The following is a description of a gene set: Abnormally increased frequency (usually defined as three or more) loose or watery bowel movements a day. studied in species Homo sapiens Human Gene Set: HP_DIARRHEA Diarrhea, and this is the list of marker genes: BTK, HPS1, ERBB2, MGME1, SLC35C1, ARPC5, ITGB3, EPCAM, SLC19A1, CTLA4, ATP6V0A1, ERCC6, C5, APOA1, AIRE, SREBF1, CARMIL2, PCSK1, SON, SLC37A4, GREM1, TGFB1, B2M, CHD7, NAGLU, TOM1, POLA1, TYMP, OPLAH, JAK3, SLC22A5, CAV1, GLA, NHLRC2, SAR1B, HSD3B7, CPT1A, NR0B1, CDKN2A, SP110, ASL, TERT, ALDOB, SCNN1A, ADAM17, IGHM, TKFC, SLC51B, IL6, RIPK1, UQCRH, KARS1, USP7, BACH2, POLG, DOLK, NFKBIA, WDR1, IL21R (interleukin 21 receptor), ACTG2, FOXN1, IDS, DPM1 (NCBI Gene Id 8813), OTULIN (NCBI Gene Id 90268), MMUT, SUGCT, SCN11A, CLPB, TCF3, ALG2, B4GALT1, MRAP, GFI1, LRRC8A, ABCD1, MT-CO1, CD109, COG6, IRF1 (interferon regulatory factor 1), HNF4A, AGR2, SMARCD2, AK2, RMRP, SHARPIN, STK11, ETHE1, LRBA, MTR, ATRX, RYR3, SYNJ1, ANO1 (anoctamin 1), CDKN2B, NGF, MPV17, TLK2, SLC26A3, ABCB4, ADNP, CD55, HS3ST6, PLVAP, DBH, ATP1A3, IL2RA, AMACR, TMPRSS15, FAS, CCR1, GDNF, IDUA, RNF113A, VPS13C, HLA-B, TTC7A, HYOU1, NAGS (NCBI Gene Id 162417), IL12A-AS1, SLC10A2, TCN2 (transcobalamin 2), DES, TNFRSF13B, GATA6, CASP8, ACSL5 (NCBI Gene Id 51703), RFX6, TREH, HGSNAT, MCM10 (minichromosome maintenance 10 replication initiation factor), SLC12A3, MEFV, ATP8B1, SLC12A1, MEN1, EFL1, KRAS, RET (NCBI Gene Id 5979), REL, F9, ANTXR2, ALG3, IFNG, TTR, COG4, ORAI1, MADD, ACVRL1, NAA10, MT-CO2, TAOK1, SKIC3, AVP, C4B, IPO8, RECQL4 (RecQ like helicase 4), PKP1, SEMA3C, ELANE, CD3G, CPT2, IGKC, F8, ALDH4A1, ITGB4, MT-ND1, DGAT1, WAS, BRCA1, PHKG2, PIGT, ITGB2, RFXANK, SAT1 (NCBI Gene Id 6303), IL2RB, ERBB3, BMPR1A, ABCB11, CARD8, EDNRB, ACAT1, LIG3, BRCA2, IGLL1, NOD2, ATP7A, MC2R, ATP6AP1, RFX5, CR2 (NCBI Gene Id 1380), IL10RA, TET2, PPP2R5D (NCBI Gene Id 5528), AKR1D1, ANAPC1, IL10, ZNFX1, SERPING1, CBL, CFHR3 (complement factor H related 3), CARD11, CDKN1A, CHD8, PHKB, ARX, CCDC47, TFRC, IRF2BP2 (NCBI Gene Id 359948), COG7, SYK, TP53, RBCK1, G6PC1, IRAK1, CAD (carbamoyl-phosphate synthetase 2, aspartate transcarbamylase, and dihydroorotase), CD79B, DMPK, FCGR2A, ZAP70, RRM2B, ACSF3, UCHL1, VPS45, MVK, LIG4, IL2RG, IFNGR1, SLC25A13, PRKN, STX3, MYD88, STAT1, ARPC1B, FBP1, RAG2 (recombination activating 2), EDN3, SNCA, HLA-DQB1, IL12A, MAOA, IFIH1, PALLD, CPOX, PIK3CD, PERCC1, RNF168, ASXL1, GNS, SPINT2, AMN, SGSH, MT-TL1, GP1BB, PLEC, NLRC4, RACGAP1 (NCBI Gene Id 94651), SAMD9, MAP3K14 (mitogen-activated protein kinase kinase kinase 14), DNAJC6, SLC19A2, KMT5B, KNSTRN, BLNK, SDHD, MT-TH, NEUROG3, APC, MCM6, CFH, FOCAD, ITCH, IL37, IL21, CYP7B1, MTTP, NCF4, F5, DDC, IKBKB, KLRC4, PMM2, PSTPIP1, HACE1, ERAP1, RAG1, STAT4, CACNA1A, GINS1, ALG8, ATP5F1A, SLC7A7, CLMP, TNFRSF1A, ATP1A2, TNFRSF13C, CLCNKB, NR3C2, ALG1, GP1BA, SCN9A, RFXAP, CD3D, SLC5A1, ITGA2B, CYP27A1, DOCK11, ADA, ALK, FAH, PODXL, SLCO2A1, EGFR, IKBKG, LIN28B, SPP1, MLYCD, PIK3R1, MYO5B, NRTN, SLC46A1, TSHR, LCK, ALAD, HEXB, ITGA2, CD247, MT-CO3, ENG, IRF4, SPI1, HEATR3, LRRK2, UBAC2, DCLRE1C, ZFYVE19, LIPA (lipase A, lysosomal acid type), PALB2, MT-TF (NCBI Gene Id 4558), IL6ST, PINK1, ZBTB24, STAT3, SRSF2, KIF23, PSMB10, PIK3CG, ACADM, ELP1, HTRA2 (HtrA serine peptidase 2), IKZF1, STAR, PGM1, HBB, MT-ND6, MPI (NCBI Gene Id 4351), GUCY2C, CD19, CFTR, MT-ND4, TXNRD2, NBN, HADH, HMBS, ALG9, CD3E, WIPF1, KIT, IL7R, LCT (lactase), ERCC8, PTEN, CFHR1, CDKN2C, ECE1, KCNJ1, WNT2B, COX15, SRP19, SEMA3D, CD40LG, RUNX1, AGA, ERCC4, DNMT3B, ELF4, TCIRG1, FCHO1, FOXP3, SMO (NCBI Gene Id 6608), DOCK2, SLC39A7, ERCC2, HMGCL, UNC45A, SAA1, DEF6, MYCN, PHKA2, C4A, PI4KA, SLC1A3, RNF31, LMO1 (LIM domain only 1), AP1S1, PHOX2B, LYN, NNT, BTD, NAXD, TRAC, UBE3C, RABL3, DNASE2, HLA-DQA1, SLC39A4, TLR4, KIF1B, SI, DNASE1L3, MT-TS2, MT-TQ, SMAD4, MT-ND5, ASAH1, IL23R, GALT, CD79A, SKIC2, HMGCS2, SLC51A, PARK7 (Parkinsonism associated deglycase), ATM, CDKN1B, MT-TW, ICOS, NSUN2, SLC9A3, CIITA